Given this list of marker genes ACOT13, GATD3, MTERF1, ARID5B, PLCL1, KARS1, IFI44, HLA-DMA, RANBP1 (RAN binding protein 1), IFI27, PHKB, TDG, GPD2 (glycerol-3-phosphate dehydrogenase 2), MIOS, FAR2, SIK3, PPBP, TRIP4, PRPSAP1, TCF4, TIA1, NUP93, ESF1 (NCBI Gene Id 55639), ACVRL1, EIF3G, ADCY7, POMP, MRTO4, SNX3, CDKAL1, FNDC3A, PBX3, GOT2, C1orf54, CERS6, TREM2, PCGF1, SERPINE1, RCN2, TMT1A, CCDC92, ZNF140, BCAT2, UQCRB, ACYP2, TTC1, PCNX4, RGS1, GTF3A, BET1, DDX23, BCAP29, TSPO, SLC39A14, POLR2B (RNA polymerase II subunit B), SLC2A5, UBE2Q1, FUBP1, BHLHE40, ATF3, RTP4, CCT6A, STXBP1, PHF10, RRAGA, STK3, RPL23AP32, PJA1, SNRPF, MAP4K5, NAGPA, MRPL15, NTAQ1, PSMD8, EHBP1, CUL1, ARL6IP4 (NCBI Gene Id 55913), CKAP5, EIF2S3, MT1HL1, GLUD2, ZFR, ZWILCH (zwilch kinetochore protein), RPL15, MCTS1, SEPTIN8, PANK2, ZNF638, ATXN10, SLC1A3, SHQ1, TCF12, RPS28, ENG, AHCYL1, TIPIN, GOLGA5, UNC50, RPA3, NECTIN2 (nectin cell adhesion molecule 2), FAM234B, AIDA, ATIC, TSPAN14, MPDU1, MRPL11, MITF, DNPEP, PIGG, CTNND1, TASP1, ACP1, ZMYND11, C10orf88, ZNF83, SLC39A4, OAS1, ZNHIT6, CENPN, APIP, CUL2 (cullin 2), CZIB, CRIP1, CLNS1A, UBL5 (ubiquitin like 5), DCK, RUBCN, COQ4, NAP1L1, WDR43, DAB2, S100A10, PRC1, RPS27, MRPL35, TRIP6, DPM3, SIL1, NDUFA1, PPID, DERA, TP53BP2 (NCBI Gene Id 7159), TMEM126B, MRPL13, COPB1, PXMP4, GALNT7, NKX3-2, GNRH1, ME2, SUV39H2, PTPRA, MAGT1, COX8A, TARDBP, ATP5MF, XRCC5, ADH5 (NCBI Gene Id 2223), RACK1, NUP88 (nucleoporin 88), CPM, LSM5, RPLP2, HADH, MAIP1, SLC25A31, ANXA2P2, TBCE, KHDRBS3, ARCN1, ZNF468, LRPPRC, ITGA2, TM2D1, APEH (acylaminoacyl-peptide hydrolase), ROCK2, CEP170, MCM10, KYNU, PAICS, UCKL1, COPB2, ENOSF1, ELOC, ITGB1, DOLK, ASPM, CPT2, CLN8, ATG101, SAE1, ABTB2, SNRPG, NOP53, DGKB, KCNA3, CHEK2, RAB33A, RPS13, SNX5, here is a description of the gene set: Human Gene Set: GSE3982_MAC_VS_NEUTROPHIL_LPS_STIM_UP from publication Jeffrey KL, Brummer T, Rolph MS, Liu SM, Callejas NA, Grumont RJ, Gillieron C, Mackay F, Grey S, Camps M, Rommel C, Gerondakis SD, Mackay CR (PMID 16474395) In the present study we used Affymetrix oligonucleotide microarrays to produce gene transcription profiles for the major leukocyte types in humans. This comprehensive dataset enabled us to not only establish which genes were expressed in each leukocyte type, but also which genes were expressed in each subset after activation. The used of a comprehensive dataset of gene profiles from all the major human leukocyte subsets enabled a novel and powerful means for identification of genes associated with single leukocyte subsets, or different immune paradigms. Genes up-regulated in comparison of macrophages stimulated with LPS (TLR4 agonist) at 4 h versus neutrophils stimulated with LPS (TLR4 agonist) at 1 h. species: Homo sapiens